The following is a description of a gene set: from publication Chen Y, Wang X (PMID 31504780) studied in species Mus musculus Genes predicted to be targets of miRBase v22 microRNA mmu_miR_3065_5p in miRDB v6.0 with MirTarget v4 prediction scores > 80 (high confidence targets). Mouse Gene Set: MIR_3065_5P, and this is the list of marker genes: Upf2, Stk3, Clasp2, Zfp462, Inpp4b, Taf5, Gm715, Mdga2, Kmt2a, Pdcl3 (NCBI Gene Id 96896), Slit1, Ftsj1, Trp63, Kcnj2, Usp7, Atxn1l, Taf4b, Scfd1, Aak1, Met, Hnrnpk, Pfdn2, Eif1b, Dnajb9, Sp4 (trans-acting transcription factor 4), Gria2, Hoxb8, Smad2, Gtf3c3, Rfx7 (NCBI Gene Id 77004), Bcl11b, Klf13, Smg1 (SMG1 nonsense mediated mRNA decay associated PI3K related kinase), Arhgap20 (Rho GTPase activating protein 20, NCBI Gene Id 76232), Kdm7a, Csgalnact1, Ufm1, Hycc2, Ireb2, Eif3j1, Map4k2, Mgam, Vmn1r132, Mecp2, Pclo, Psd3, Taf7l, Nrxn3, Cpeb2, Crebzf, Ddx3x, Prrg1, Rgs13, Zfp148, Eif1ax, Gria4, Ntpcr, Slc39a10, Nmu, Trim52, Ugcg, Ophn1, Calcrl, Lrrcc1 (leucine rich repeat and coiled-coil domain containing 1), Zbtb11, Yrdc, Mmgt1, Plgrkt (NCBI Gene Id 73839), Hsd17b7, Magohb, Esp15, Ttc23l, Slc35e2, Flrt2, Egr4, Atp6v1a, Dach1, Nbdy, Glce, Azin1, Kif3c, Ddo, Nucks1, Zdhhc17, Spink10, Trps1, Phactr3, Sdr16c5, Eif3j2, Mybl1, Cdk17, Pals1, Pum2, Rbm41, Agtr1b, Rasgef1a, Ror1, Dck, Notch2, U2af2, Spsb1, Guf1, Brd8dc, Gnpnat1, Gls, Tshz3, Trappc6b, Rif1, Pdcd10, Cxcr4, 4930524B15Rik, Wtap, Pcdh9, Ccnt2, Maz, Ankrd13c, Ikzf5, Spin4, Nlgn3, Sox14, Chrnb1, Pkia, Nufip2, Mllt3, Slitrk1, Nr2c1, Cfap161, Septin7, Smndc1 (survival motor neuron domain containing 1), Prr5l (NCBI Gene Id 74608), Zfp111, Ssb, Hycc1, Cyp2u1, Gpa33, Chsy3, Homer2, Kpna4, Plekha8, Kcnt2, Ralgds, Arpp21, Rpusd2, Scaf11, Sec61a2, Sbno1, Tulp4, Dkc1, Tbc1d15, Strbp (spermatid perinuclear RNA binding protein), Tspan33, Zfp654, Dpp6, Hapln1, Hs3st1, Faxc, Crim1, Ccng2, Pik3cb, Ccrl2, Reps2, Spink5, Chordc1, Neurod1, Errfi1, Son, Slc30a4, Rcor3, Scn8a, Dpp4 (NCBI Gene Id 13482), Ski, Camkk2, Irf2bpl, Zfp609, Minpp1, Disp2, Spp1, Eid2b, Gm14744, Aco1, Kdf1, Kctd3, Ceacam9, Dlg2, Ncs1, Otud4, Gria3, Tm2d1, Atxn1, Tle1, Adgrb3, Slc66a2, E130308A19Rik, Hs2st1, Gsx2, Btn1a1, Ube2d1, St3gal1, Pias2, Atl2, Ankrd45, Pnma5, Hace1, Nxf3 (nuclear RNA export factor 3), Col19a1 (collagen, type XIX, alpha 1), Grk2, Rnf8, Btf3l4, Chst13, Dcp1a, Bbx, Cep76, Sema3d, Lsm14b, Col5a2, Fmn2, Pdp2, Col4a3 (NCBI Gene Id 12828), Klf11, Nlgn1, Kdm2a, Cacna2d2, Sorcs1, Srsf7, Foxc1, Ttc33, Jade1, Brd4, Rabgap1, Mecom (NCBI Gene Id 58253), Tsen34, Atp2b4, Clec10a, Gse1, Zfp800, Slc35b4 (solute carrier family 35, member B4), Cep170, Yme1l1, Chrna3, Unc93a, Snx18, Lcp1, Mdfic, Khdrbs3, Dync1li2, Crp, Hnrnpul2, Lrrc8a, Tlnrd1, Tomm70a, Trmt112, Rapgef2, Lrrn1, Nova2, Rhebl1, Esyt2, Acvr1c, Spast, Ino80d, 2510039O18Rik, Samd8, Semp2l2a, Cul4b, Wdr44, Rap2c, Brdt (NCBI Gene Id 338496), Senp8, Zic3, Slc17a6, Ranbp3l, Tgds, Hmgb1, Sema4c, Synj2bp, Fzd7, Nr4a3, Nxpe4, Lrp12 (low density lipoprotein-related protein 12), Tmem167, G3bp1, Arid4b, Cdk2, Nexmif, Tasor2, Cep83, Cdnf, Nsd3, Sec22b, Srsf10, Srsf11, Ube3a, Epha7, Rybp (RING1 and YY1 binding protein), Dpysl2, Ppfia2, Tnks (tankyrase, TRF1-interacting ankyrin-related ADP-ribose polymerase), Etnk1, Ift46, Car8, Acsf2, Edem3, Klf12, Med13l, Sox7, Klf10, Flrt3, Pik3ca, Vps41, 5430402E10Rik, Tcea1, Atad2, Usp2, P2ry1 (purinergic receptor P2Y, G-protein coupled 1), Serpine1, Tbc1d8b, Mbnl1, Foxc2, Myb, Tmc1, Meis1, Or51ab3, Igf1, Cpsf6, Zbtb1, Cstf3, 6030458C11Rik, Vps4b, Usp3, Acsl3, Hecw2 (NCBI Gene Id 329152), Slc9a6, Pank3, Rbm25 (RNA binding motif protein 25), Acaca, Kctd9, Zfp704, Zfp292, Ints2, Rbms3, Wwc2, Apobec3, Tfcp2, Ccdc121rt1, Lmo7, Kcnj3, Sgip1, F11r, Dennd5b, Pafah1b1, Ncam1, Chic1, Vps37a, Ptgr2, Zfp518b, Emp2, Kansl1l, Fgd4, Plekhf2, Zfand5, Klhl20, Vmn1r148, Rab1a, Foxp1, Cxxc5, Jmjd1c, Ewsr1, Prtg, Myf5, Ash1l, Fgf13, Cir1, Srp9, Nppb, Mtx3, Fam174a, Zeb1, Slc66a3 (solute carrier family 66 member 3), Eml4, Wnk1